The following is a description of a gene set: from publication Miyara M, Yoshioka Y, Kitoh A, Shima T, Wing K, Niwa A, Parizot C, Taflin C, Heike T, Valeyre D, Mathian A, Nakahata T, Yamaguchi T, Nomura T, Ono M, Amoura Z, Gorochov G, Sakaguchi S (PMID 19464196) Gene expression profiles of subsets of CD4+ T cells according to their expression of FoxP3 and CD45RA were compared. FoxP3 is a key transcription factor for the development and function of natural CD4+ regulatory T cells (Tregs). Here we show that human FoxP3+CD4+ T cells are composed of three phenotypically and functionally distinct subpopulations: CD45RA+FoxP3low resting Tregs (rTregs) and CD45RA-FoxP3high activated Tregs (aTregs), both of which are suppressive in vitro, and cytokine-secreting CD45RA-FoxP3low non-suppressive T cells. The proportion of the three subpopulations characteristically altered in cord blood, aged individuals, and patients with immunological diseases. Terminally differentiated aTregs rapidly die while rTregs proliferate and convert into aTregs in vitro and in vivo as shown by the transfer of rTregs into NOD-scid-common gamma-chain-knockout mice and by TCR sequence-based T cell clonotype tracing in peripheral blood of normal individuals. Taken together, the dissection of FoxP3+ cells into subsets enables one to analyze Treg differentiation dynamics and interactions in normal and disease states, and to control immune responses through manipulating particular FoxP3+ subpopulations. Genes down-regulated in comparison of PTPRC- CD4 T cells versus non-suppressive T cells. species: Homo sapiens Human Gene Set: GSE15659_CD45RA_NEG_CD4_TCELL_VS_NONSUPPRESSIVE_TCELL_DN, and this is the list of marker genes: SMC1A, SLC16A11, TMEM63B, YIPF2, PLCB2, TP63, PNPT1, GFUS, SCARF2, RENBP, SHB, TBC1D4, ZAN, SPCS2, TCEAL8, STK25, NOTCH2, TPMT, SUN1, ZFAND5, SEMA6A, TP53, SUSD4, STK16, PPP1R16A, SMAP2, TMEM97, PSPN, NECTIN4, PIGV, PIGW, UBL3, ZNF579 (zinc finger protein 579, NCBI Gene Id 163033), RGS17, PPP1R13L, SNED1, SAMSN1, TOP3A, TEX12, TMEM126A, STING1, ZNF432, RAB8B, TUBD1, ZNF277, RANBP9, STXBP5L, THBD, SEC11A, SHMT2, ST7-AS1, POLR3F, S1PR2, SLC43A2, ENTR1, PRDX3, ZNF131, PEAR1, TCP10L3, ZNF687, ZNF341, ZC3H15, PRODH, ZNF354C, S100A16, TRPM6, SNAP91, RALGAPA1, SLFNL1, RND2, PRR9, TMEM80, UNC13D, SLC25A3, SPARC, TRIP6, TRAPPC6B, ZNF316, RASA1, SLC25A46, TLR4, SEC14L1, PDLIM2, SYN2, TGM6, PLD2, THRB, TRIM36, SEMA4A, SMAD1, ZNF394, SLC4A9, USP43, SLC9A8, RTN4, ZNF287, NDST2, ZMIZ2, TMSB4Y, TUBB4B, SKI, PKD2L1, UBA6, PTH2R, SRL, ZSCAN29, UGT2B17, PLK4, ZNF747, PILRA, S100P, KRBOX5, SPATC1, SLC35E2A, RD3, STC2, ZFP69B (NCBI Gene Id 65243), RRAGB, ZNF430, WARS1, TTC7A, PXDNL, PLB1, ZNF34, AFG2B, SDCCAG8, TOMM22, RNF141, SEC24D, SPATS2L, SARS2, RIT1, IL13RA2, PSKH2, PLEKHM3, RGL3, ZCCHC9, RAB35, RPS3A, THEMIS2, PYGL, TBX3, RBM41, ZNF142, UBE2D1, TMCO6, SEPHS2, RANGRF, UTP11, TLL2, REM2, PUSL1, PRAM1, RNF150, THAP1, SETD1B, ZNF200, THBS2, TRIM16, PEX2, TEX11, SLC43A3, SLC22A18, TMEM158, RAB2B, UTP18, PCGF1, WIF1, RAB11FIP4, ZNF557, SSH2, SLC26A11, RTP1, RASD1, PLEKHH3, PPY, PIK3AP1, EIPR1, PSMG2, STK32A, SGO2, PYHIN1 (pyrin and HIN domain family member 1), SLC8B1, ZSCAN12, USP9X, RNF214, PLIN4, UBE2U, UBA3, TNFSF12, USP11, TRABD, SPACA7, ZNRF2, TULP2, PLEKHA8, PKD2L2, TTTY13, TK1